Given this list of marker genes Col14a1, Ccl8, Dpt, Spon1, Cxcl14, Pdgfrl, Mfap2 (NCBI Gene Id 17150), Aif1, H2-Ea, Casp4, H2-Aa (histocompatibility 2, class II antigen A, alpha), Bcl2a1b (NCBI Gene Id 12045), Tsc22d1, H2-DMb1, Dcn, Mmp14, Cdca3, Fcer1g, Igsf10, Cd74, Lad1, C3, Col4a1, Col3a1, Ccl2, Matn2, Cx3cl1, Ccr2, Ifitm3, Cxcl12, Mgp, Vcam1, Socs3, Pirb, Ccl5, Angptl4, Nid1, H2-M3, Pf4, Pdgfra, H2-Ab1, Icam1, Postn, Ltb, Isg15, Fbn1, Sparc, Osmr, Mfap4, Iigp1, S100a6, Psmb9, Vim, Iglv1, Fcgr3, Sycp1, Col15a1, Adam8, Tgfbr2, Cidec, H2-Eb1, Irf1, Psmb8, Tlr2, Serpine1, Sparcl1, Ccn2, Cxcl10, Cmtm3, Tnfsf13b, Lsp1, Col18a1, Efemp2, Ccl6 (NCBI Gene Id 20305), Lum, Pycard, Col1a2, S100a4, Igfbp2, Tgfbi, Cfh, Bok, Ogn, Adamts2, Bbc3, H2-DMa, Ltbp2, Col1a1, here is a description of the gene set: from publication Kim YS, Kang HS, Herbert R, Beak JY, Collins JB, Grissom SF, Jetten AM (PMID 18227149) studied in species Mus musculus Mouse Gene Set: KIM_GLIS2_TARGETS_UP To obtain insight into the physiological functions of the Krüppel-like zinc finger protein Gli-similar 2 (Glis2), mice deficient in Glis2 expression were generated. Glis2 mutant (Glis2(mut)) mice exhibit significantly shorter life spans than do littermate wild-type (WT) mice due to the development of progressive chronic kidney disease with features resembling nephronophthisis. Glis2(mut) mice develop severe renal atrophy involving increased cell death and basement membrane thickening in the proximal convoluted tubules. This development is accompanied by infiltration of lymphocytic inflammatory cells and interstitial/glomerular fibrosis. The severity of the fibrosis, inflammatory infiltrates, and glomerular and tubular changes progresses with age. Blood urea nitrogen and creatinine increase, and Glis2(mut) mice develop proteinuria and ultimately die prematurely of renal failure. A comparison of the gene expression profiles of kidneys from 25-day-old/60-day-old WT and Glis2(mut) mice by microarray analysis showed increased expressions of many genes involved in immune responses/inflammation and fibrosis/tissue remodeling in kidneys of Glis2(mut) mice, including several cytokines and adhesion and extracellular matrix proteins. Our data demonstrate that a deficiency in Glis2 expression leads to tubular atrophy and progressive fibrosis, similar to nephronophthisis, that ultimately results in renal failure. Our study indicates that Glis2 plays a critical role in the maintenance of normal kidney architecture and functions. Partial list of genes up-regulated in the kidney of GLIS2 knockout mice compared to the wild type.